The following is a description of a gene set: studied in species Homo sapiens Human Gene Set: MIR4437 from publication Chen Y, Wang X (PMID 31504780) Genes predicted to be targets of miRBase v22 microRNA hsa-miR-4437 in miRDB v6.0 with MirTarget v4 prediction scores > 80 (high confidence targets)., and this is the list of marker genes: TMEM231, SGO2, ITSN1, NGEF, KRTAP4-9, GSTCD, HSD11B2, MOGAT3, CLEC19A, FREM3, BOK, GNG13, GDE1, PPP1R3E, LYSMD1, KCNMB2 (potassium calcium-activated channel subfamily M regulatory beta subunit 2), ZNF292, GALNT10, ICAM4, WDPCP, ATG4C, CEP43, PTGFRN, TBC1D12, RNF11, CNOT6, PDXDC1, SEMA4B, RCBTB1, KRTAP4-11, ADGRL2, PRSS8, STX1B, AAK1, KRTAP4-8, SH3PXD2A, CCDC88A, H2BW2, ZNF48, POU4F2, HACD3, SETD5 (NCBI Gene Id 55209), GLUL, B4GALT1, DCAF17, RASSF1, MFN2, JAK1, ACTR3C, BCL6B, FUT10, ARMC10, FKBP4, PTPRM, CFLAR, BPHL, KDM2A, PRKCE (protein kinase C epsilon), NAT8L, OASL, TCF19, GIPC3, RASGEF1A (RasGEF domain family member 1A), UBE2Q2, HUS1B, IPP, ANTXR1, NR2C1, PRDM1, GK5, SPRED1, WIZ, CABP4, FBXL18, C14orf180, MAVS, KIF21B, COA3, MMP16, UBE2D2, NIT1, CC2D1B, RGMB, ARL11, RRP7A, FAT3, RRH, CLMP, RELB (NCBI Gene Id 5971), ADAM23, DCLRE1B, ADCYAP1R1, PNPLA5, MYH10, HPS1, VPS45, TUBGCP5, CUL5, HTRA3, MCUR1, FGF9, MEF2A, ESRP2